Given this list of marker genes Acsl4, Atp5pf, Abcc4, Tnfrsf11a, Ptgs2, Tnfsf11, Pla2g4a, Nos2, Il1b, Edn1, Mapk9, Pla2g3, Ptges, P2rx7, Oxt, Pla2g10, Mif (NCBI Gene Id 17319), P2ry2, Lep, Il1a, Map2k6, here is a description of the gene set: Mouse Gene Set: GOBP_PROSTAGLANDIN_SECRETION The regulated release of a prostaglandin, any of a group of biologically active metabolites which contain a cyclopentane ring, from a cell or a tissue. studied in species Mus musculus